Given this list of marker genes GRIN2D, ZNF384, ZMYND11, SLIT3 (NCBI Gene Id 6586), HS2ST1, ACOT9, RCOR2, ASB15, KDM6A, LMNA (lamin A/C), CALCB, MB21D2, HOXB9, CUEDC1, HEBP2, HOXD12, ZNF503, UBE2M, FES, RASAL2, ADAMTS1, NFRKB, KIF7, DHX30, SCN3B, ESRRG, GNAO1, ZMYND8, SPATA20 (spermatogenesis associated 20), CTNND1, METTL4, HAS2, GDPD2, TSKU, CRYAB, NDUFA4L2, KCNK3, PRDM10, KCNH2, GPR173, KAZN, RHO, POU2F1, PTCH2 (patched 2), NTN1, MCRS1, LOXL3, ERBB3, ZNF362, ARHGAP33, EXTL3, NTN3, PYGM, BCL2L2, NMT1, CXXC5, ANKRD13B, PHF21B, HOXC5, MAPK10, PTK7, RBM39, FAM110D, RAB1B, MAP1B, RAB11A, EFEMP2, SP6, NDC80, THRA, FGF10, VAMP3, LINC01312, RPS4X, SLITRK3, ANP32A, TAL1, SAFB, LAMC2, PAX6, HOXA11, SEMA3B, CYYR1, CTSK, OSBPL2, ITPR1, GEMIN4, FOLR1, ANGPTL2, CA10, TRAF3IP2, DOCK6, FSTL3, MUSK, NUCKS1, KLHL10, GABRG2, PCBP4 (NCBI Gene Id 57060), CRNN, CNTFR, DHRS3, PURA, KCND2, CD160, NFYB, INKA2, SIPA1, ZNF532, NEGR1, RAC1, CETN3 (centrin 3), CA14, NRG1, MEA1, ARL5B, NFAM1, SIX4, PPRC1, FOXA2, CDK5R2 (NCBI Gene Id 8941), DOK1 (docking protein 1), HSPB7, DYNLL1, FAM91A1, TEAD3, TGIF1, CTDSP1, TNNI1, IMPDH1, PHF6, SULF1, FMNL1, NKX2-8, STX16, NKX2-2, HSPB2, RBM12, GNAS, BECN1, SH3BP1, TRERF1, CCDC71L, GPRC5C, NT5C3B, RHBDL3, MAP7D1, MAP1A, PRDM8, RBMS1 (RNA binding motif single stranded interacting protein 1), TAFAZZIN, FBRS (NCBI Gene Id 8734), PPP1R8, CRB2, NRXN1, IL11, EPHB1, STK35, PAQR6, CASZ1, NLGN2, CYP26A1, NHLH1, MTUS1, KCNK4, PIANP, LITAF (NCBI Gene Id 9516), FANCD2, GPHB5, NLGN3, GLI1, PRMT1, CYP26B1, PIGA, PRR35, LRRTM3, DMTN, HOOK2 (hook microtubule tethering protein 2), HPCA, LHX6, PIM1, TIMP4, ZNF521, BCL3, PCDH10, MAF, BCL11A, UCHL1, NFATC4, GABRA1, PHF12, PTPN14, NELL2, MAEA, WNT10B, FAXDC2, DLGAP4, OGT, EFNA4, THRAP3, CHST3, FOXP1, SYNCRIP, PPP1R16B, MARCKSL1 (MARCKS like 1), CA9, TNNC2, MYOC, ZFP91, PI4KB, GABRA3, COL7A1, TLK2, CLTC, HOXA10, HOXB8, LRP1, GJB1, PIP4K2A, ZER1, ATP2B4, HEXIM2, MAP4K2, LRP8, FBXL20, P2RX1, MAST2, ETV6, HOXD13, GHR, HOXA7, MEGF8 (NCBI Gene Id 90198), PRX, CDK6 (NCBI Gene Id 1021), DLL4, PTCH1 (NCBI Gene Id 8015), TMEM255A, GRIK3, TIMP3, KAT5, BCL2L1, ATXN7L2, MRGPRF, HOXD3, MPZL3, DCAKD, ZNF462, PAGR1, ZSWIM8, CPNE1, STAG2, MYCN, REL, CYB561D1, FSTL1, GPR85, here is a description of the gene set: species: Homo sapiens Human Gene Set: ZIC3_01 Genes having at least one occurrence of the motif NGGGKGGTC in the regions spanning 4 kb centered on their transcription starting sites. This matches the ZIC3 transcription factor binding site V$ZIC3_01 (v7.4 TRANSFAC).